The following is a description of a gene set: from publication Jazaeri AA, Yee CJ, Sotiriou C, Brantley KR, Boyd J, Liu ET (PMID 12096084) Human Gene Set: JAZAERI_BREAST_CANCER_BRCA1_VS_BRCA2_DN BACKGROUND: Germline mutations in BRCA1 and BRCA2 are responsible for 5%-10% of epithelial ovarian cancers, but the molecular pathways affected by these mutations are unknown. We used complementary DNA (cDNA) microarrays to compare gene expression patterns in ovarian cancers associated with BRCA1 or BRCA2 mutations with gene expression patterns in sporadic epithelial ovarian cancers and to identify patterns common to both hereditary and sporadic tumors. METHODS: Tumor samples from 61 patients with pathologically confirmed epithelial ovarian adenocarcinoma with matched clinicopathologic features were studied, including 18 with BRCA1 founder mutations, 16 with BRCA2 founder mutations, and 27 without either founder mutation (termed sporadic cancers). The cDNA microarrays contained 7651 sequence-verified features. Gene expression data were analyzed with a modified two-sided F test, with P<.0001 considered statistically significant. The expression level of six genes was also studied with reverse transcription-polymerase chain reaction. RESULTS: The greatest contrast in gene expression was observed between tumors with BRCA1 mutations and those with BRCA2 mutations; genes showed statistically significantly different expression levels (P<.0001). This group of genes could segregate sporadic tumors into two subgroups, BRCA1-like and BRCA2-like, suggesting that BRCA1-related and BRCA2-related pathways are also involved in sporadic ovarian cancers. Fifty-three genes were differentially expressed between tumors with BRCA1 mutations and sporadic tumors; six of the 53 mapped to Xp11.23 and were expressed at higher levels in tumors with BRCA1 mutations than in sporadic tumors. Compared with the immortalized ovarian surface epithelial cells used as reference, several interferon-inducible genes were overexpressed in the majority of tumors with a BRCA mutation and in sporadic tumors. CONCLUSIONS: Mutations in BRCA1 and BRCA2 may lead to carcinogenesis through distinct molecular pathways that also appear to be involved in sporadic cancers. Sporadic carcinogenic pathways may result from epigenetic aberrations of BRCA1 and BRCA2 or their downstream effectors. Down-regulated genes distinguishing between breast cancer tumors with mutated BRCA1 from those with mutated BRCA2. species: Homo sapiens, and this is the list of marker genes: RCL1, TAL1, FOXO1, BABAM2, APEX1, RYBP, BMP6, PMEPA1, POLR2A, SBNO1, PTEN, YTHDC2 (YTH N6-methyladenosine RNA binding protein C2), CD83, SUGP2, TRMT6, GOLGA1, WNT2, NCOA1, PLXNA2, ZBTB14, ARHGEF6, PDGFRB (platelet derived growth factor receptor beta), RGL2, GABRP, SRSF11, CD36, RGS16, ZNF211, MMP13, ITGAE, PON1, SFRP4, PTPRM, RGS1, CSRP2, IL7, PDE6A, MAST1, CSNK1E, GFM2, SYT17, KDR